The following is a description of a gene set: species: Homo sapiens Human Gene Set: REACTOME_NEUREXINS_AND_NEUROLIGINS Neurexins and neuroligins, and this is the list of marker genes: HOMER1, GRM1, CASK, APBA2, EPB41L5, GRM5, GRIN2D, DLGAP4, NLGN1, SHANK1, EPB41L1, DLGAP3, DLG2, SYT10, BEGAIN, LRRTM1, SHARPIN, DLGAP1, NRXN3, LIN7A, LIN7C, HOMER3, DBNL, SYT12, LIN7B, SYT9, STXBP1, NLGN4X, DLGAP2, NLGN4Y, PDLIM5, DLG3, SHANK2, LRRTM3, SYT1, LRRTM2, APBA1, SIPA1L1, STX1A, NLGN3, NRXN2, GRIN2C, DLG4, LRRTM4 (leucine rich repeat transmembrane neuronal 4), SYT2, SYT7, APBA3, EPB41L3 (erythrocyte membrane protein band 4.1 like 3), NRXN1, NLGN2, GRIN1, EPB41L2, EPB41, GRIN2B, GRIN2A, HOMER2